Given this list of marker genes VANGL1, SATB2, SPSB3, ORMDL2, SPIRE2, PFDN2, PTPRG, UGGT2, TSHZ2, TSNAXIP1, PELI1, ECPAS, MMEL1, OLFML3, WASF1, WDR4, YARS1, TNFSF13B, MMP1, MXD4, RGS20, TAL2, TOM1, RGS17, EIPR1, TBCB, PHKG2, NBEA, TWIST2, KIF17, SIX4, LIPG, RNPS1, NAPB, RHOBTB2, PSMB1, MRM1, MAN2C1, SYNE1, NOP2, SEMA3B, TXNDC9, MYO1B, MYCT1, MRPS25, TIMP3, PI16, POLR2F, PGR, SHBG, VASN, MYL9, RAD51B, TBC1D20, KIF1A, TRMT1, REEP6, KIF20A, UROC1, SYCP3, SOD3, SFTPC, NELL2, PNPT1, NUDT9, MYO6, SART1, NCAM1, TJP2, SUV39H2, TNFRSF1A, PTPN4, NRARP, PTN, TSPY1, TNFRSF8, SCML4, MSRB2, RPF2, PCLO, STX1A, RBM4B, SEZ6L, PREB, RALGPS2, SIAH1, MKLN1, TRPC6, TRIM54, MVK, SLC25A53, ZBP1, LCMT2, MOB1A, MRTFB, SPOCK2, TAX1BP3, TOR1B, STIL, MAN2B2, SNAP29, SYTL2, MOGAT2, TUBB4A, WFDC1, PI4K2A, RPS6KB1, CIMAP1A, NHERF2, YPEL3, UPK3A, LAMA2, OTP, PRR15, NPY2R, ORAI1, PTPRM, PLEKHB1, MARCKSL1, SEMA4F, RFXANK, MRRF, LAMC2, MINK1, MAN1B1, TRAM1L1, ONECUT3, MAP4K2 (mitogen-activated protein kinase kinase kinase kinase 2), SLC17A3, MMP23B, TTL, STRADA, TUB, TBCC, THAP7, TLL1, MYCN, STK32B, TNNI1, ZSCAN21, SCGN, TCP1, RHBDD3, KLHDC2, TECTB, SHARPIN, RAD51C, TNS2, LY6G6C, MGAT4C, KRTCAP2, LY96, ZFP1, SMR3A, RGS4, SLC25A20, SRPX2, TFF2, TBX6, MLLT3 (MLLT3 super elongation complex subunit), TBX19, SYT12, TMEM50B, MRPL1, SH3D19, TOMM7, MRPL12, PLCG2, STMN3, TFAP2B, SNRNP70, ELOC, MYB, PIP4K2A, MYOZ2, UROS, SLC9B2, MTF1, RIN1, VTI1A, LTC4S, TC2N, MAP2K3, NDUFB2, PARVB (parvin beta), PRKCSH, PURB, TMEM176A, MMP17, MTERF4, RAG1, SPON2, TLL2, PSMG4, SIX2, PSMB9, NDUFB7, TNFSF4, NPPC, here is a description of the gene set: Genes down-regulated in comparison of control dendritic cells (DC) at 0 h versus those stimulated with poly(I:C) (TLR3 agonist) at 0.5 h. Human Gene Set: GSE17721_CTRL_VS_POLYIC_0.5H_BMDC_DN studied in species Homo sapiens mouse primary BMDCs were stimulated with tlr ligands and gene expression changes were profiled on Affymetrix arrays from publication Amit I, Garber M, Chevrier N, Leite AP, Donner Y, Eisenhaure T, Guttman M, Grenier JK, Li W, Zuk O, Schubert LA, Birditt B, Shay T, Goren A, Zhang X, Smith Z, Deering R, McDonald RC, Cabili M, Bernstein BE, Rinn JL, Meissner A, Root DE, Hacohen N, Regev A (PMID 19729616)